Given this list of marker genes Inpp5d, Ocrl, Ptpmt1, Ptprq, Inpp5b, Inpp5e, Inpp5k, Synj2, Fig4, Inpp5j, Synj1, here is a description of the gene set: Catalysis of the reaction: 1-phosphatidyl-1D-myo-inositol 4,5-bisphosphate + H2O = 1-phosphatidyl-1D-myo-inositol 4-phosphate + phosphate. Mouse Gene Set: GOMF_PHOSPHATIDYLINOSITOL_4_5_BISPHOSPHATE_5_PHOSPHATASE_ACTIVITY species: Mus musculus